The following is a description of a gene set: species: Homo sapiens Human Gene Set: MIR6768_5P from publication Chen Y, Wang X (PMID 31504780) Genes predicted to be targets of miRBase v22 microRNA hsa-miR-6768-5p in miRDB v6.0 with MirTarget v4 prediction scores > 80 (high confidence targets)., and this is the list of marker genes: CD81, WDR82, UBAP2, RMND5A, ZZZ3, CNOT6L, SUSD6, MKX, HDLBP, TENM4, RAB14, CAMKK2, COL4A1, NR2F2, RNF145, ROCK2, RAB6B, C6orf136, SGSM2, LATS2, ITGA6, TET1, PITX2, CCDC50, GNAO1, PIEZO2, FCGR3A, CD164L2, BEND4, CSDE1, GSK3A, ZMYM6 (zinc finger MYM-type containing 6), ADH5, TMEM64, SEH1L, RRM2, CARD10, EDIL3, NKX2-2, PCSK6, WAC, ARHGAP35, SLC16A12, TRIM71, CEP350, DNM3, B4GALT1, PHF6, TP53INP1, NREP, UBE4A (ubiquitination factor E4A), IGF2BP2, FOXO4, TLR2, NGFR, NEDD1, PRDM1, ZNF124, ADAMTS15, MAP7D2, HSPA1A, GPATCH2L, SLC18A1, PLEKHB2, ARHGAP12, ZMAT2, SPINK2, CXXC5 (NCBI Gene Id 51523), HECTD4, RIMS2, ABAT, TPTEP2-CSNK1E, CTBP1, ZCCHC18, MOBP, CNST, PSEN1, NWD2, EIF4ENIF1, NEURL1B, WNK1, ZNF605, FAM151B, TTC29, INO80, TRHDE, HOXA7, BRWD1, BRPF3, SRSF6, WDR7, PRKCD, LRRC1, RAD50, RBPMS2, LIN28B, CHD6, NIP7, MAP3K8, DENND5B, SMAP2, INTS6, SYNPO2L, PLPP3, SIKE1, INPP5K, DYRK1A, SKIDA1, SRSF10, NAA16, CBLL1, ACVR2A, PLAA (phospholipase A2 activating protein), CELF1, HNRNPA0, DOCK4, MYO18B, HSDL1, CHAF1A (NCBI Gene Id 107985297), RAI1, ZNF792, TMEM158, RGS7BP, DCAF7, KPNA1, OSBPL11, WBP1L, UBN2, NAB1, ADGRB3, RAPH1, TP53INP2, NAA30, MIA3, HINT1, SPOPL, DOCK3, MAP4K4, TRUB1, GLCCI1, HERC2, MXD1, CDKN1B, SNX8 (sorting nexin 8), DCK, KCTD20, PSD3, VCF1, ABCA1, NECTIN3, R3HDM1, APC (NCBI Gene Id 324), CRISPLD2, FZD1, GLIS3, ZFHX4, SNX12, SNX30, ADAMTSL3, PI15, PUM1, WDFY3, KCTD4, ARHGAP17, PCMTD2, NCOA4, SMCHD1, CX3CR1, GRPEL2, ZNF385B, NF1, SAMD4A, SYT1, DNM1L, ARHGAP21, TNRC6B, ADAT2, SFRP1, UBR5, KLC1, FMR1, CHMP4B, ABL2, MED15, ADCYAP1, MGAT4A, KLF5, ZFHX3, KLHL13, ZMIZ1, ZEB1, ZBTB46, CTCF, BCL9, CSNK1E, PJA2, GRIA4, PTBP3